The following is a description of a gene set: Defects in MMACHC cause methylmalonic aciduria and homocystinuria type cblC (MMAHCC; MIM:277400). MMAHCC is the most common disorder of cobalamin metabolism and is characterized by decreased levels of the coenzymes adenosylcobalamin (AdoCbl) and methylcobalamin (MeCbl). Affected individuals may have developmental, haematologic, neurologic, metabolic, ophthalmologic, and dermatologic clinical findings. Reactome Pathway: Defective MMACHC causes MAHCC part of: Defects in cobalamin (B12) metabolism studied in species Homo sapiens, and this is the list of marker genes: MMACHC